The following is a description of a gene set: studied in species Homo sapiens Genes down-regulated in C57BL6 CD4 CD8 double positive thymocyte transgenic for the BDC2.5 TCR incubated with no peptide 0h versus NOD CD4 CD8 double positive thymocyte transgenic for the BDC2.5 TCR incubated with no peptide 0h. Human Gene Set: GSE2128_C57BL6_VS_NOD_THYMOCYTE_DN from publication Zucchelli S, Holler P, Yamagata T, Roy M, Benoist C, Mathis D (PMID 15780994) Fetal thymic organ culture (FTOC) DC2.5 CD4+CD8+ thymocytes from B6g7 or NOD background. 0 or 16 hour after addition of the BDC mimitope, and this is the list of marker genes: WDR48, RLN1, ZEB2, HOXA2, TOX4, ACAP1, SMPDL3B, TMEM245, RITA1, VPS13C, SWAP70, RGS14, MC5R, CFAP107, PHF1, HHEX, SPNS1 (SPNS lysolipid transporter 1, lysophospholipid), SLC11A1, TBC1D22B, GPRIN3, GID8, SELENBP1, SAFB, S100A8, DPPA5, DTX1, RYR3, H3C14, TMEM50B, FBXO28, DEDD2 (death effector domain containing 2), PRCC, TRIM63, SFXN5, PNCK, ITPR1, IBA57, PMM1, RAP2A, PRDM10, SLITRK4, SYK, GLUD1, PYM1, ARAP3, SELENOM, CLPTM1L, HSPA2, PEX1, RNF213, EBF1, HOOK3, INPP4B, LINS1, STX16, SLC15A3, TBCK, NOCT, KRT20, CST8 (NCBI Gene Id 10047), NUDT15, FZR1, SPARCL1, ZNF839, PDE1A, TLR3, CD244, ABCA7, XPO4, TENM1, CYC1, TRIM24, CXCL10, LBP, GEM, TRIM46, LRTM2, TRADD, SLCO6A1, CYBA (cytochrome b-245 alpha chain), MPDZ, NUBP2, PPFIBP1, TMUB2 (NCBI Gene Id 79089), ITSN1, SGK3, KCNT2, POU4F1, STAT2, SNX10, DAP3, MTMR7, WASHC4, RNF19A, PDXK, HBS1L (NCBI Gene Id 22991), C8A, DAPL1, CFAP43, GPER1, MTHFD2, MYH10, ATRN, FAM151B (family with sequence similarity 151 member B), SRPX, TMEM198, RIC1, PPM1F, KLHL14, TECPR1, PPP1R14C, LXN, AMHR2, RASSF4, NKX2-2, TESC, GPR15, ZBTB37, NBAS (NCBI Gene Id 51594), ITGB1, LAMTOR1, GLT6D1, ZBTB12, CD6, FIRRE, GTPBP6, CC2D2B, GMPPB, RB1CC1, PER3, PLCB3, EQTN, HRAS, NCALD, BCAN, PPP1R13B, DNASE1L1, CASQ2, RIGI, CEMIP2, NCKAP1, ATG7, ASB11, ACO2, S1PR4, PRR11, NHLH2 (nescient helix-loop-helix 2), P3H1, GSN, CD22, DCUN1D4, HID1, LITAF, HIC2, H3-5, C2CD4B, DCST1, PIEZO1, MAGT1 (NCBI Gene Id 84061), FFAR4, MAP1LC3A, NIBAN2, TXNL4B, NCOR2, FAP, LHCGR, C1QTNF7, USP10, GALNT1, STX2, RWDD4, CAMK2B, PCYOX1L, LONP1, TUT7, NAPRT, CAP1, PCDHB15, FLII, PCED1A, RBM45, DDX47, KRR1, PI4K2A, STK35, AGMO, TELO2, NUP54, ABCA3, PTDSS1, PI4KA, GRAMD4, GIP, UQCC3, APEX2, ARTN, GORASP2, PDXP, PRPF8, PAK2